Given this list of marker genes SPR, SPHK2, SPTSSB, ASAH2, SPTLC3, DHFRP1, PCBD2, ABCA2, GBA1, ACER3, PCBD1, DHFR (NCBI Gene Id 203373), SPTLC2, QDPR, ACER1, SPHK1, ASAH1 (N-acylsphingosine amidohydrolase 1), GCH1 (GTP cyclohydrolase 1), AGK, SPTSSA (NCBI Gene Id 171546), SPTLC1, ACER2, PTS, here is a description of the gene set: The chemical reactions and pathways resulting in the formation of a diol, any alcohol containing two hydroxyl groups attached to saturated carbon atoms. Human Gene Set: GOBP_DIOL_BIOSYNTHETIC_PROCESS studied in species Homo sapiens